Given this list of marker genes TMEM94, SCEL, CYP2A6 (NCBI Gene Id 82212), PSMC2, TBCA, HAUS3, IFT27, PDIA5, CDH8, ILK, YJU2, NPHP4, THOP1, SOX2, GNA15, TNFAIP1, DGKA, DENND2B (DENN domain containing 2B), DHX38, HIVEP1, OSER1, GPRIN2, GOT1, CHKB, RNPS1, HAGH, TERF2, PAICS, AMFR, HIC2, NPAS1, ASS1, PEX10, JOSD1, SARAF (store-operated calcium entry associated regulatory factor), FBXW11, AMHR2, TRPM1, FYN, TSR3, SERPINE2, DOCK2, H2AC6, TSC2, PIK3C2B, UBN1, MATR3, FHIT, ZNF500, ITPKA, PLEKHM2, CLASP1, AKAP10, F7, RNF13, BARD1, MIPEP, ATP6V1H, CUL1 (NCBI Gene Id 8454), RNPEP, POU2F2, NDUFS7, NCOA4, CPB2 (carboxypeptidase B2), CNN3, DKK4, PCDH1, PROX1, KATNB1, MUSK, KAT6B, ZNF337 (NCBI Gene Id 26152), SCN9A, ZNHIT1, REM1, KIF2A, TCERG1, CCNH, HMOX1, ATP1B2, GPATCH8, GLO1, CCNYL7, WNT5A, OPTN, ARTN, C1orf216, PEBP1, UQCRFS1, SPINK4, UBE2A (NCBI Gene Id 7319), PSMB2, CLK3, ROCK1, EXOSC8, NUP58, SRP9, SHOX, NHP2, PARVB (NCBI Gene Id 29780), DHX16, MAPK3, AFAP1, HNRNPA2B1, CX3CL1, KDM5D, BECN1, DOLK, CRKL, CYC1 (cytochrome c1), TAF11, RTN4, NDUFB3, SDC1, FAM120A (NCBI Gene Id 23196), TP63, GNRH2, SEMA3D, SLC35A1, EMD, POM121L9P, HSPA6, B3GAT3, PCYT1B, HINT1, GAS6, CLTB, RABGGTB, KATNA1, CCL7, DUSP2, ID3, MOB1A, ECPAS, CADM1, RNF126, TAF9, PRPH, LRRC8B, KHSRP, ADCY3, HCFC1, ADSL, PCBP2, SEC13, GSK3A, IQSEC2, SNRK, SARS1, ETFA, SH3BP5, CHAF1A, WSB2, ANGPTL7, ZNF593, NKX2-8, NR2F2, DYRK1A, XPOT, SF3B4, CLDND1, GRIP2, GYPB, RPS6KA2, PICALM, CNKSR2, DAP, ETHE1, ST3GAL2, STARD13 (StAR related lipid transfer domain containing 13), ARHGEF1, IFI44, ALDH1A2 (NCBI Gene Id 8854), RAPGEF5, OCEL1, HLA-J, TRIM13, TUBGCP3, KLF6, CRADD, ENOX2, MUC6 (mucin 6, oligomeric mucus/gel-forming), CAT, RAB32, DLEC1, PCDHGA8, CDH16, TBCB, CD37, HTR2A, MOBP, ARIH1, EIF2B4, ABCF1, CBX3, FEN1, GUCY2C, NDUFA6, MRFAP1L1, RRBP1, here is a description of the gene set: Monocyte-derived dendritic cells (DC) and macrophages (MΦ) generated in vitro from the same individual blood donors were exposed to five different pathogens, and gene expression profiles were assessed by microarray analysis. Responses to Mycobacterium tuberculosis and to phylogenetically distinct protozoan (Leishmania major, L. donovani, Toxoplasma gondii) and helminth (Brugia malayi) parasites were examined, each of which produces chronic infections in humans yet vary considerably in the nature of the immune responses they trigger. from publication Chaussabel D, Semnani RT, McDowell MA, Sacks D, Sher A, Nutman TB (PMID 12663451) Human Gene Set: GSE360_CTRL_VS_B_MALAYI_LOW_DOSE_MAC_DN studied in species Homo sapiens Genes down-regulated in comparison of macrophages versus macrophages exposed to B. malayi (5 worms/well).